Given this list of marker genes CDH23, CPLX3, DAG1, EGFLAM, CACNB2, PACSIN1, ATP2B1, SH3GL2, here is a description of the gene set: A ribbon synapse between a retinal photoreceptor cell (rod or cone) and a retinal bipolar cell. These contain a plate-like synaptic ribbon. studied in species Homo sapiens Human Gene Set: GOCC_PHOTORECEPTOR_RIBBON_SYNAPSE